Given this list of marker genes CD99L2, PRTN3, PIK3CG, FUT7, JAML, PIK3CD, PECAM1, RIPOR2, ADAM8, CD177, CD99, MDK, IL1R1, XG, here is a description of the gene set: Human Gene Set: GOBP_NEUTROPHIL_EXTRAVASATION The migration of a neutrophil from the blood vessels into the surrounding tissue. studied in species Homo sapiens